The following is a description of a gene set: species: Mus musculus Any process that activates or increases the rate or extent of growth, the increase in size or mass of all or part of an organism. Mouse Gene Set: GOBP_POSITIVE_REGULATION_OF_GROWTH, and this is the list of marker genes: Smo, Akt1, Sema7a, Zpr1, Mfsd2a, Fgf8, Pex5 (peroxisomal biogenesis factor 5), Crk, Mir467a-4, Csnk2a1, Ntn1, Il9r, Bdnf, Dlg1, Cacng7, Cxcl12, Mapk1, D1Pas1 (NCBI Gene Id 98517), Extl3, Mlst8, Tbx20, Mir155, Hbegf, Cpne9, Rpl4, Armc12, Map3k13, Mir467a-3, Slc6a3, Tbx5, Pafah1b1, Adrb2, Adcy10, Limk1, Exosc2, Prox1, Adam10, Sema4d, Dio3, Gpam, Fgf9, Rhoa, H3f5, Cd38, Capn3, Map2k5, Sgip1, Nrp1 (NCBI Gene Id 270112), Pls1, N6amt1, Syt1, Agrn, Ep300, Mtor, Map1b, Sash3, Mir21a, Uts2r, Syt2, Mtm1, Bmp10, Hyal1, Nipbl, Cep43, Eif4g1, Ghrl, Eif2b2, Ezr, Agr2, Mul1, Pum2, Rag2 (NCBI Gene Id 19374), Ghrh, Adnp, Derl2, Tgfb2, Cdkl5, Avpr1a, Erbb4, Exosc4, Rasal1, Usp47, Prkn, Myo5b, Sdcbp, Sfrp2, Ucn, Mir675, Ist1, Ybx3, Ahr, Mecp2, Trip10, Drd2, Vil1, Cdc42, Cntf, Tead1, Parp2, Sema5a, Sphk1, Ppib, Slc25a33, Rptor, Zfyve27, Megf8, Il9, Ncbp1, Lpar3, Rnf157, Bcl11a, Anapc2 (anaphase promoting complex subunit 2), Gh, Actn3, Igf1, Cacna2d2, Ddx49, Cxcr4, Rims2, Cpne5, Prr5, Lrp1, Cpne6, Mapk14, Ccnd2, Arx, Myod1, Trim32, Zp3, C3, Cfl1, Fn1, Igfbp1, Zfpm2, Akap6, Rnd2, Sirt1, Gdi1, Vegfa, Taf9b (NCBI Gene Id 407786), Lgi1, Crabp2, Sox15, Tnfrsf12a, Flt4, Ptk2, Ghrhr, Klhl22, Fgf2, Plcb1, Bbs2, Slc9a1, Hamp, Fdps, Atp8a2, Cxcl16, Ncoa3, Mir467a-5, Rps6kb1, Picalm, Edn1, Chd7, Tgfbr1, Ptk2b (PTK2 protein tyrosine kinase 2 beta), Fgfr1, Igf1r (insulin-like growth factor I receptor), Ino80, Lep, Acacb, Dll1, Mir467a-8, Pin1rt1, Trpv2, Dnph1, Ncam1, Shtn1, Nr3c1, Musk, Hlx, Nrg1 (neuregulin 1), Hamp2, Stat5a, Tbx1, Kdm2b, Slc25a4, Il7, Yap1, Macf1 (microtubule-actin crosslinking factor 1), Serpine1, Mkks, Ndel1, Sh3glb1, Gata4, Hpn, Ghsr, Adam17, Ddx3x, Sfn, Ilk, Cdkn2aip, Trpc5, Smad7 (SMAD family member 7), Sh3pxd2b, Mir467a-1, Rims1, Acsl4, Mmp14, Fxn, Efna5, Csf1, Mir467a-9, Mir467a-2, Avp, Rbpj, Hopx, Cib1, Armc10, Supv3l1, Ahi1, Foxs1, Cdk1, Slc23a2, Mir467a-7, Syt3, Afdn, Syt17, Plaa, Cryaa (NCBI Gene Id 16930), Ngf, Adrb1 (NCBI Gene Id 11554), Ptger4, Hdgfl2, Cyfip1, Mtpn, Hnrnpk, Tfcp2l1, F2, Flt3, Pabir1, Dbn1, Erbb2, Rictor, Gsk3b, Mir467a-10 (microRNA 467a-10), Prkdc, Dscam, Syt4, Notch1, Hsf1, Mapkap1, Apoe, Cyba (NCBI Gene Id 13057), Hmga2, Ntrk3, Cdh4, Gpr21, Igf2, Agt, Commd5, Smurf1, Bbs4, Ikzf1, Zfp639, Exosc9, Eif4g2, Ccnb1, Ppm1f, Wnt3a, Mapt, Creb1, Islr2, Slc44a4, Sfrp1, Insr, Dbnl, Egfr, Celf1, Brat1, Krt17, Dcx, Mir467a-6, Srf, Pou4f2, Serp1, Gli1, Bmpr1a, Bmpr2, Rftn1, Pou1f1, Rufy3, Tbx2, Arhgap32, Psmd10, Wnt5a, Reg1, Nedd4l, Pak1, Sptbn4, Wfs1, Wt1, Ddx39b (NCBI Gene Id 68389), Mef2c, Itsn2, Hey2, Twf2, Ccn4, Disc1, Pou3f2, Tgfbr3 (transforming growth factor, beta receptor III), Pin1, Stat5b, L1cam, Ghr, Fgfr2, Golga4, Gata6, Wnt2, Pim1, Tshr, Unc13a, Sgk1 (serum/glucocorticoid regulated kinase 1), Bcl2, Ppard (peroxisome proliferator activator receptor delta), Wnt3